The following is a description of a gene set: Here we have used a systems biology approach to study innate and adaptive responses to vaccination against influenza in humans during three consecutive influenza seasons. We studied healthy adults vaccinated with trivalent inactivated influenza vaccine (TIV) or live attenuated influenza vaccine (LAIV). TIV induced higher antibody titers and more plasmablasts than LAIV did. In subjects vaccinated with TIV, early molecular signatures correlated with and could be used to accurately predict later antibody titers in two independent trials. Notably, expression of the kinase CaMKIV at day 3 was inversely correlated with later antibody titers. Vaccination of CaMKIV-deficient mice with TIV induced enhanced antigen-specific antibody titers, which demonstrated an unappreciated role for CaMKIV in the regulation of antibody responses. Thus, systems approaches can be used to predict immunogenicity and provide new mechanistic insights about vaccines. species: Homo sapiens Genes up-regulated in monocyte 7d vs 0d in young adults (18-50) after exposure to Fluarix/Fluvirin, time point 7D from publication Nakaya HI, Wrammert J, Lee EK, Racioppi L, Marie-Kunze S, Haining WN, Means AR, Kasturi SP, Khan N, Li GM, McCausland M, Kanchan V, Kokko KE, Li S, Elbein R, Mehta AK, Aderem A, Subbarao K, Ahmed R, Pulendran B (PMID 21743478) Human Gene Set: NAKAYA_MONOCYTE_FLUARIX_FLUVIRIN_AGE_18_50YO_7DY_UP, and this is the list of marker genes: DYNC2I1, BCL11A, RFXANK, AVL9, MED6, ANKRD36B, CD22, MAPKAPK2, RNF24 (NCBI Gene Id 51262), SRD5A1, FCER1A, NRIP2, S100PBP, FAM149B1, SEL1L3, NAXD, TRIM37, H1-2, SCAMP1, RAB3GAP1, RIOX2, CCL4, CDC14A, HMGA1, COBLL1, BET1, PPP1R15A, RBM12B-AS1, ID2, GBE1, SNAPC5, P2RY14, SLC10A1, TARDBP, UNC45A, ATF7IP, SLC38A1, IARS1, CD300A, ZNF692, TRMT11, NFX1, ID2B, RBM3, PRKCI, STEEP1, XPO1, PRMT2, OXCT1, SMC6 (NCBI Gene Id 79677), INSR, MCM3, SPTBN1, SIRT3, MDFIC, EGR1, FLT3, IER5, FUBP1, UBE2H, BTAF1, ITIH2, UEVLD, DLG5, ZFP64, SCAF11 (NCBI Gene Id 9169), CLN5, MACROH2A1, GPR75 (NCBI Gene Id 10936), AAK1, OGT, SUGP2, ARAP3, KHDC4 (KH domain containing 4, pre-mRNA splicing factor), SNCA, SMC5, ALK, BCL3 (NCBI Gene Id 602), MYL5, SPIN2B, MTMR3, WWP2, NPR3, SPIN2A (spindlin family member 2A), ASNS, SIGLEC9, DUSP10, ST20, FKBP8